The following is a description of a gene set: Human Gene Set: GOCC_FEMALE_PRONUCLEUS The pronucleus originating from the ovum that is being fertilized. studied in species Homo sapiens, and this is the list of marker genes: TET3, METTL23, STPG4, CBX1, DPPA3, SLC2A1, AKAP8, RIF1, TBP, CCNA2